Given this list of marker genes ACTR1A, PLK4, DCTN3, STAG1, XPO1, CEP43, RANBP2, SSNA1, TUBA1A, DYNLL2, BUB1, CENPJ, DYNC1I2, TUBB1, NEK7, CDCA8, STAG2, CCNB1, ZWILCH, NDE1, CDK5RAP2, DSN1, AKAP9, NEK6, CENPQ, NDC80, CENPC, CEP250, RAD21, SMC1A, CSNK2A2, TUBA3D, TUBA1B, TUBB4B (tubulin beta 4B class IVb), CSNK2A1, CCNB2 (NCBI Gene Id 9133), KIF18A (NCBI Gene Id 81930), CEP76, TUBG1, DYNLL1, CENPM, TUBB8, B9D2, CLASP1, CENPU, CEP290, CETN2 (NCBI Gene Id 812), TAOK1, CENPT (NCBI Gene Id 80152), NSL1, SKA1, TUBGCP6, NUP43, HAUS1, YWHAE, CEP152, DYNC1LI2, CEP78, BUB3, TUBGCP2, CDC20, NCAPH, PRKAR2B, KIF2A, PAFAH1B1, PPP2R5D, CEP72, HAUS4, WAPL, NCAPD2, NCAPG, HAUS7, CENPL, PMF1, DCTN1, CENPA, CNTRL, HAUS6 (HAUS augmin like complex subunit 6), AURKB, CEP135, NUDC, CEP41, TUBAL3, CEP57, PCM1, TUBB2A, TUBA4B, HAUS2, CENPF, KIF2C, ZW10, PPP1CC, PPP2R5B, BUB1B, CENPH, MAD2L1, NEK9, DYNC1LI1, HDAC8, NUF2, SMC2, TUBGCP5, MZT1, TUBB4A (NCBI Gene Id 1864), TUBB8B, SPC24, SMC3, RCC2, HSP90AA1, PLK1, NME7, MAPRE1, DCTN2, CENPN, MIS12, MZT2B, PPP2R5A, KNTC1, PPP2R1A, CEP63, NUP98, ODF2, EML4, RANGAP1 (NCBI Gene Id 6381), CENPO, NUP160, SPDL1, CDCA5, FIRRM, NUP37, TUBB, CENPI, NUP133, TUBGCP3, SMC4, CEP70, TUBA1C, CEP164, CEP192, ERCC6L, CSNK1D, CENPS, CCP110, CLASP2, CENPK, PRKACA, TUBA3E, CENPE, TUBG2, MAD1L1, CLIP1, PPP2R5E, HAUS5, NINL, ITGB3BP, NDEL1, RPS27, KIF2B, INCENP, SEC13, CKAP5, PCNT, PDS5B, SFI1, CENPP, NUP107, CSNK2B, TUBB2B, AHCTF1, CEP131, NEDD1, HAUS3, SEH1L, OFD1, DYNC1I1, TUBB6, DYNC1H1, ZWINT, PPP2CB, SKA2, SGO2, TUBA3C, PPP2CA, TUBGCP4, NUP85, PDS5A, TUBA4A (tubulin alpha 4a), SPC25, CSNK1E, CDK1, BIRC5, PPP2R5C, TUBB3, SDCCAG8, HAUS8, YWHAG, NEK2, TUBA8, NUMA1, SGO1, KNL1, PPP2R1B, ALMS1, MZT2A, here is a description of the gene set: Mitotic Prometaphase species: Homo sapiens Human Gene Set: REACTOME_MITOTIC_PROMETAPHASE